The following is a description of a gene set: Human Gene Set: MIR142_3P species: Homo sapiens from publication Chen Y, Wang X (PMID 31504780) Genes predicted to be targets of miRBase v22 microRNA hsa-miR-142-3p in miRDB v6.0 with MirTarget v4 prediction scores > 80 (high confidence targets)., and this is the list of marker genes: RGL2, ANK3, QKI, RBM47, MORF4L2, NUCKS1, DCUN1D4, PSMB5, NR3C1, MTMR9, AFF1, FOXO4, DUXA, MARK3, VAMP3 (NCBI Gene Id 9341), ZNF90, JMJD1C, ROCK2, ITGAV, UTRN (utrophin), PAFAH1B2, ARF4, CPEB2, ITGA8, LRRC32, PDZD9, APC, LCOR, S1PR3, TNKS (NCBI Gene Id 8658), SP4, TASOR2, PTPRB, STAU1, CCDC6, IPO7, CEP192, MBD6, PCGF3, WASL, ITPR3, KLHDC1, HGS, SLC37A3, RASSF3, CCNT2, LRRC3B, CLOCK, ANKRD11, HECTD1, ASH1L, ZEB2, NR1D2, COG4 (component of oligomeric golgi complex 4), C5orf24, ZMYND8, NR2F6, FOXD4L6, SLC1A3, RHOBTB3, RHEB, RICTOR (NCBI Gene Id 253260), GAB1, C6orf47, SMG1, CLTA (clathrin light chain A), SLC49A4, CIITA, RAC1, RLF, ADGRL3 (NCBI Gene Id 23284), PTPN23, RNF126, BMAL1, ARID5B (AT-rich interaction domain 5B), IPMK, SLC35F5, ZCCHC14, HEATR5A, ACSL4, TAOK1, MTCH1, ZNF479, SYN2, PHAF1, MLXIP, OSBP, FMNL2, AKT1S1, KAT2B, USP33, SLC33A1, EGR2, TGFBR1, RAB3A (NCBI Gene Id 96387), HMGA2, RAB11FIP2, CDADC1, USP6NL, TIPARP, SP8, TMEM59, LRRC1, STX12, SYPL1, GAS2L3, PDE4B, TMEM200B, GNB2, PLCB1, ADCY9, GHR, PPP1R2, ATF7IP, SUCO, OSBPL3, ATXN1L, RAB2A, MTUS1, C9orf72, BNC2, XPO1, KDELR2, FGF9, IL6ST, INPP5A, ZBTB41, ATP6V1G3, GNAQ, CHMP3, RNF103-CHMP3, SLC7A11, KIF5B, STRN3, PLA2G12A, TARDBP, FOXD4L3, DNAAF9, PUM1, BTLA, MOB4 (NCBI Gene Id 96815), TAB2, ACBD5, RAB12, ANKRD42, CFL2, WDR5B, BRWD3 (bromodomain and WD repeat domain containing 3), MRFAP1, TSEN34, STAM, PGM1, SH2B1, LRP1B, ITGB8, CDC25C, IRAK1, RARG, BOD1, CLDN12, BAZ1A, CTTN, ITPKB, MYH10, TWF1, INPP5F, RERE, PPP1R37, GTF2A1, ZEB1, HSPE1-MOB4, TNRC18, TET3, EIF5A, IER3